The following is a description of a gene set: The chemical reactions and pathways by which arachidonic acid is converted to other compounds including epoxyeicosatrienoic acids and dihydroxyeicosatrienoic acids. Human Gene Set: GOBP_EPOXYGENASE_P450_PATHWAY studied in species Homo sapiens, and this is the list of marker genes: CYP2C8, CYP2F1, CYP2C19, CYP2A7, CYP1A2 (NCBI Gene Id 1544), CYP1A1, CYP1B1, CYP2A6, CYP2E1, CYP4F12, CYP4A11, CYP2A13, CYP2B6, CYP2C9, CYP4F2, CYP2J2, CYP2S1